The following is a description of a gene set: species: Homo sapiens Genes predicted to be targets of miRBase v22 microRNA hsa-miR-6806-5p in miRDB v6.0 with MirTarget v4 prediction scores > 80 (high confidence targets). Human Gene Set: MIR6806_5P from publication Chen Y, Wang X (PMID 31504780), and this is the list of marker genes: GOLPH3, RALA, ZMAT3, NIPSNAP2, ABCG2, TMPRSS12, DCN, ADAM10, EIF2S2, PUS10, ANKFY1, PCNX1 (NCBI Gene Id 23690), PCMTD1, GLS, GLIPR1, TAOK1 (NCBI Gene Id 80214), B3GNT6, RET, HTR2C, CHN1, MIER1, TSC22D2, ILRUN, SMAD1, CMC2, FNIP2, CADPS, BIVM, TRIM29, LRRCC1, TIMM23B, NTNG2, PRDM5, CEP85L, TTC17, PLAG1, GSPT2, CPEB1, NLRP1, HERC5, TTBK1, GSPT1, ZBTB25, NUMB, KRT85, DEPDC4, ATP2B1, NEK3, CSMD3, RORA, ZFP3, SEC11A, TIMM17A, TMEM33, PHACTR2, CDC14A, AKR1D1, ATL2, MTFR2, LIFR, UGCG, ENPEP, RPGRIP1L, SNX18, DYNAP, KRTAP3-1, ANXA10, SRSF10